Given this list of marker genes TEAD4, WWTR1 (WW domain containing transcription regulator 1), TEAD2, TEAD1, CCN2, TEAD3, RUNX3, YAP1, here is a description of the gene set: part of: Transcriptional regulation by RUNX3 species: Homo sapiens Association of RUNX3 with the TEADs:YAP1 complex inhibits loading of the TEADs:YAP1 to the CTGF promoter, thus negatively regulating transcription of the CTGF gene which encodes the Connective tissue growth factor. Reactome Pathway: RUNX3 regulates YAP1-mediated transcription